Given this list of marker genes Scn8a, Gpc1, Cd164, Efemp2, Rbpj, Twist1, Tnnt2, Egr1, Zfp689, Egln1, Fgfrl1, Sox15, Bmp2, Hey2 (NCBI Gene Id 30802), Luc7l, Mir669a-9, Cav1 (caveolin 1, caveolae protein), Erbb3, Mtss1, Wt1, Nln, Lif, Hdac5, Norad, Hey1, Bmp4, Kras, Creb1, Six4, Homer1, Tbx20, Nras, Ednra, Boc, Cntf, Flnb, Egr2, Pitx2, Rhoa, Mir214, Ankrd2, Cryab, Mir669a-6, Fktn, Fgf8, Actn3, Six1, Rcan1, Alx4, Trim72, Smad3, P2rx2, H1f5, Mir143, Klhl41, Stac3, Usp19, Myoz1 (NCBI Gene Id 80553), Emd, Sirt1, Mapk14, Klk1b1, Cenpf, Myl6, Nrg1, Tcf7l2, Lemd2, Met, Fbxo22, Dsp, Mylk2, Pkp2, Casq1, Sap30, Unc45b, Ttn, Vps54, Snhg15, Tafazzin (tafazzin, phospholipid-lysophospholipid transacylase), Mettl8, Myhas, Rtl1, Dmrta2, Mir669a-10, Xbp1, Hdgfl2, Shox2, Gtf3c5, Jph1, Lama5, Cops2, Frg1, Col3a1, Unc45a, Tgfb2, Foxc2, Csrp3, Sirt2, Smad4, Ski, Lox, Gpx1, Fhl1, Tgfbr3 (transforming growth factor, beta receptor III), Lmod3, Tbx1, Dmd, Zfpm1, Shh, Cflar, Heg1, Ube4b, Plagl1, Fkrp, Hdac7, Dll4, Xirp2, Myt1, Hmg20b, Etv1, Heyl, Prox1, Asb2, Lrp6, Vax1 (ventral anterior homeobox 1), Selenon, Mymx, Ero1a, Foxp1, Prr14, Myl2, Tmem182, Tgfbr1, Dtnbp1, Chrna1 (NCBI Gene Id 99038), Dpf3, Zfpm2, Ripor2, Isl1, Bcl9, Msx1, Foxc1, Eng, Skil, Hspa8, Fgfr2, Ep300, Vps13b, Vangl2, Eln, B4galnt2 (NCBI Gene Id 14422), Stra6, Epor, S100b, Cacna1s, Atf3, Zfp609, Ccnt2, Angpt1, Vamp5, Adgrb1 (adhesion G protein-coupled receptor B1), Large1, Nphs1, Gja1, Neurl1a, Tnni1, Ctnnb1, Smo, Mir669a-7, Mylk, Rbm24, Ly6e, Notch1, Myf5, Zbtb42, S1pr1, Snw1 (SNW domain containing 1, NCBI Gene Id 66354), Eid2, Chd7, Synb, Phox2b, Fos, Col11a1, Ryr2, Neurog1, Gata4, Paxbp1, Tifab, Cfl2, Pou4f1, Tcap (NCBI Gene Id 21393), Mnx1, Mir669a-5, Hdac9, Hlx, Fzd2, Nr2f2, Meox2, Meg3, Ephb1, Myh14 (myosin, heavy polypeptide 14), Gsc, Wnt2 (NCBI Gene Id 93808), Svil, Mir669a-3, Ybx3, Chkb, Zfhx3, Hsd17b1, Sin3b, Nfix, Igf2, Ky, Myf6, Negr1, Hand1, Fzd1, Bves, Vgll2, Xk, Mir145a, Or10j5, Ddx17, Psma6, Btbd1, Ddx5, Asnsd1, Megf10, Fkbp1a, Pmp22, Tnnc1, Scx, Pdlim3, Fxr1, Bdnf, Uqcc2, Spg11, Dag1, Chd2, Hoxd10, Myocd, Wnt10b, Mettl21c, Bmp10, Ankrd1, Vrk3, Ass1, Rbfox1, Hottip, Lncpint, Mbnl1, Gpcpd1, Usp2, Gm34220, Col19a1, Plec, Actc1, Mkx, Tcf23, Des, Klhl40, Adrb2, Tgfb1, Nr4a1, Pitx1, Bcl2, Kmt5b, Kel, Sgcb, Tcf21, Nkx2-5, Flot1, Mef2c, Kat8, Tnni3, Nupr1, Nr1d2, Rps6kb1, Myl3, Srpk3, Ldha, Lef1, Popdc2, Mir669a-2, Maff, Smyd1, Lbx1, Myoz2, Bcl9l, Id3, Tcf15, Arid5b, Cntnap1, Crhr2, Mtm1, Ppp3cb, Cavin4, Klf5, Sfmbt1, Smad7, Foxp2, Ccm2l, Myh7, Cdk5, Il6, Myod1, Col6a1, Mir669a-1, Myom1, Rpl3l, Foxl2, Mir669a-4, Mybpc3, Dll1, Bmpr1a, Chat, Med20, Ankrd33, Myc, Foxo4, Sox8, Btg2 (NCBI Gene Id 98237), Abcc9 (ATP-binding cassette, sub-family C member 9), Lmna, Myh6, Mir675, Chrnd, Pax3, Med1, Cyp26b1, Epo, Hoxd9, Disp1, Bmal1, Wnt3a, Cdon, Nfatc3 (nuclear factor of activated T cells, cytoplasmic, calcineurin dependent 3), Cntfr, Mymk, Hmgcr (NCBI Gene Id 218474), Acta1, Cav2, Hivep3, Ppif, Ptcd2 (pentatricopeptide repeat domain 2), Foxn2, Ryr1, Tpm1, Hdac4, Myorg, Smtnl1, Prkaa1, Gmppa, Mcub, Zbtb18, Jph2, Nog, Mstn, Barx2, Msc, Mylpf, Myl6b, Hlf, Cntnap2, Dner, Scn11a, Mrtfb, Itgb1, Myog, Ppp3ca, Mir669a-8, Foxh1, Mef2d, Naglu, Eomes, Bin3, Lrp2, Lemd3, Sox11, Coprs, Akirin1, Pax7, Tll2, Rxra, Rb1, Cited2, Serp1 (NCBI Gene Id 28146), Foxk1, Adarb1, Fgf3, Popdc3, Nf1, Pax5, Mustn1, Sirt6, here is a description of the gene set: The process whose specific outcome is the progression of the muscle over time, from its formation to the mature structure. The muscle is an organ consisting of a tissue made up of various elongated cells that are specialized to contract and thus to produce movement and mechanical work. studied in species Mus musculus Mouse Gene Set: GOBP_MUSCLE_ORGAN_DEVELOPMENT